The following is a description of a gene set: Human Gene Set: SCHLINGEMANN_SKIN_CARCINOGENESIS_TPA_DN Malignant transformation of mouse skin by chemical carcinogens and tumour promoters, such as the phorbol ester 12-O-tetradecanoylphorbol-13-acetate (TPA), is a multistage process that leads to squamous cell carcinoma (SCC) formation. In an effort to identify tumour-associated genes, we studied the influence of short-term TPA-treatment on the gene expression profile of murine skin. A comprehensive microarray with some 5,000 murine gene specific cDNA fragments was established and hybridised with pooled RNA derived from control and TPA-treated dorsal skin samples. Of these genes, 54 were up- and 35 were down-regulated upon TPA application. Additionally, we performed suppression subtractive hybridisation (SSH) with respective RNA pools to generate and analyse a cDNA library enriched for TPA-inducible genes. Expression data of selected genes were confirmed by quantitative real-time PCR and Northern blot analysis. Comparison of microarray and SSH data revealed that 26% of up-regulated genes identified by expression profiling matched with those present in the SSH library. Besides numerous known genes, we identified a large set of unknown cDNAs that represent previously unrecognised TPA-regulated genes in murine skin with potential function in tumour promotion. Additionally, some TPA-induced genes, such as Sprr1A, Saa3, JunB, Il4ralpha, Gp38, RalGDS and Slpi exhibit high basal level in advanced stages of skin carcinogenesis, suggesting that at least a subgroup of the identified TPA-regulated genes may contribute to tumour progression and metastasis. from publication Schlingemann J, Hess J, Wrobel G, Breitenbach U, Gebhardt C, Steinlein P, Kramer H, Fürstenberger G, Hahn M, Angel P, Lichter P (PMID 12640676) studied in species Mus musculus Down-regulated in murine dorsal skin cells at 6 h after treatment with the phorbol ester carcinogen TPA., and this is the list of marker genes: COL1A1, TMEM255A, ENO3, SH3GLB2, ACSBG1, APOC1, CCL27, COL1A2 (NCBI Gene Id 1278), THRSP, DOC2GP, CD247, MXRA8, GPT, CCDC28B, CCL21, TCAP, DEAF1, PLEKHA5, GMPR, RSRP1, ITM2B (NCBI Gene Id 9445), ANKRD17, AEBP1, GRN, HOXA7, ZBTB17